The following is a description of a gene set: Cluster 6 of aberrantly hypermethylated genes in blasts from AML (acute myeloid leukemia) patients. We hypothesized that DNA methylation distributes into specific patterns in cancer cells, which reflect critical biological differences. We therefore examined the methylation profiles of 344 patients with acute myeloid leukemia (AML). Clustering of these patients by methylation data segregated patients into 16 groups. Five of these groups defined new AML subtypes that shared no other known feature. In addition, DNA methylation profiles segregated patients with CEBPA aberrations from other subtypes of leukemia, defined four epigenetically distinct forms of AML with NPM1 mutations, and showed that established AML1-ETO, CBFb-MYH11, and PML-RARA leukemia entities are associated with specific methylation profiles. We report a 15 gene methylation classifier predictive of overall survival in an independent patient cohort (p < 0.001, adjusted for known covariates). Human Gene Set: FIGUEROA_AML_METHYLATION_CLUSTER_6_UP studied in species Homo sapiens from publication Figueroa ME, Lugthart S, Li Y, Erpelinck-Verschueren C, Deng X, Christos PJ, Schifano E, Booth J, van Putten W, Skrabanek L, Campagne F, Mazumdar M, Greally JM, Valk PJ, Löwenberg B, Delwel R, Melnick A (PMID 20060365), and this is the list of marker genes: IRAK3, EXOC1, GUCY1B1, EXOSC3, CALCOCO1, YBX3, CBLN4, PLPBP, MAP7, RSKR, MAP7D2, PIAS2, LANCL1, TP53INP2, DYNC1LI1 (NCBI Gene Id 51143), TIGD3, PABPN1, ZSCAN32, HNF4A, SMIM15, COCH, ZNF343, WBP1L, KRT81, GDF3, BPGM, FAM83B, PFN2, MANBA, MT2A, OSBPL1A, MRPS21, PPIL6, INO80C, SAP30BP, KCNAB3, ELAVL2, GPAT4, HOXA2, FBXL7, MAP7D3, SMPD2, CUL9, ZFR, FGF20, PIGZ, MAD1L1, TNFAIP8L2, REXO2, AMOTL1, NFIX, MCTS1, AEBP1, ZNF582 (zinc finger protein 582), MRPL9, CASP12, EXOSC2, CCDC34, TANC2, GTF2A1, TNPO3, PPT2, ZSCAN1, SCG5, PTPN14, OAZ3, PHC1, ZNF454, TAF3, ABLIM1, PHF13, GPRASP3, FAM131A, IFNAR2, RAB22A, EDEM1, ZNF174, ZBTB14, NNAT, TADA2B, KNSTRN, CANT1, C19orf33, MYL4, TRAPPC1, CYP26C1, CRHBP, EFNB3, ZNF560, BTAF1, FARP2, NRP2, THBS4, ICA1L, GSN-AS1, ZNF667, CLIC2, PRRT1, CNTROB, TMEM263, ADGRG6, STX18, PMAIP1, NTN5, TMEM185B, TGFBR1, RIPPLY3, VWF, BTBD3 (BTB domain containing 3), JOSD1, SYDE2, ITGAV, C3orf38, ACOX3, SPHK2, IL11RA, DPYSL4 (dihydropyrimidinase like 4), SNRNP70, IPO8, PPP2CA, TEK, HNRNPD (NCBI Gene Id 548), CFAP184, VPREB3, DEPDC1B, HMHB1, FUT9, DNM3, RECQL5, PAQR5, SLC25A51, SLC7A8, ZCCHC14, POU5F1, CENPV, CASP2, LBX2, SGPP2, SLC66A1LP, DHRS12